Given this list of marker genes CD9, SERPINE2, PRKG1, CEACAM1, C1QTNF1, SH2B3, ADAMTS18, ALOX12, PRKCD, UBASH3B, TMX1, here is a description of the gene set: Any process that decreases the rate, frequency or extent of platelet aggregation. Platelet aggregation is the adhesion of one platelet to one or more other platelets via adhesion molecules. studied in species Homo sapiens Human Gene Set: GOBP_NEGATIVE_REGULATION_OF_PLATELET_AGGREGATION